The following is a description of a gene set: Mouse Gene Set: GOBP_POSITIVE_REGULATION_OF_HYDROGEN_PEROXIDE_METABOLIC_PROCESS Any process that increases the frequency, rate or extent of the chemical reactions and pathways involving hydrogen peroxide. studied in species Mus musculus, and this is the list of marker genes: Mfn2, Nnt, Nox4, Duoxa2, Sod2, Duoxa1, Zfp13, Snca